The following is a description of a gene set: Carbonic anhydrases reversibly catalyze the hydration of carbon dioxide and directly produce bicarbonate and protons, bypassing the formation of carbonic acid. Carbonic anhydrase deprotonates water to yield a zinc-hydroxyl group and a proton which is transferred to external buffer molecules via histidine or glutamate residues in carbonic anhydrase. The hydroxyl group reacts with carbon dioxide in the active site to yield bicarbonate. A water molecule displaces the bicarbonate and the reaction cycle begins again. There are currently 12 known active carbonic anhydrases in humans. part of: Metabolism species: Homo sapiens Reactome Pathway: Reversible hydration of carbon dioxide, and this is the list of marker genes: CA1, CA13, CA5B, CA7, CA3, CA14, CA5A, CA6, CA12, CA4, CA9, CA2